The following is a description of a gene set: studied in species Homo sapiens Human Gene Set: GOBP_KIDNEY_MESENCHYME_DEVELOPMENT The biological process whose specific outcome is the progression of a kidney mesenchyme from an initial condition to its mature state. This process begins with the formation of kidney mesenchyme and ends with the mature structure. Kidney mesenchyme is the tissue made up of loosely connected mesenchymal cells in the kidney., and this is the list of marker genes: SIX1, WT1, BASP1, AMER1, WNT4, SIX2, TCF21, PAX2, BMP7 (NCBI Gene Id 655), SMAD4, STAT1, PKD2 (polycystin 2, transient receptor potential cation channel), OSR1, SHH, SIX4, MYC, FOXD1